The following is a description of a gene set: The posttranscriptional addition of methyl groups to specific residues in a tRNA molecule. species: Homo sapiens Human Gene Set: GOBP_TRNA_METHYLATION, and this is the list of marker genes: TRMT12, TRMT1L, THUMPD3, ALKBH8, TRMT9B, NSUN2, TRMT10A, METTL8, TRMT44, METTL2A, WDR6, TRMT61A, TYW3, WDR4, THUMPD2, TRMT6, TRDMT1, TARBP1, BCDIN3D, AKT1, METTL1, TRMT10B, NSUN3, HSD17B10 (hydroxysteroid 17-beta dehydrogenase 10), METTL2B, TRMT1, TRMT112, TRMT10C, TRMT5, FTSJ1, MTO1 (NCBI Gene Id 25821), TRMT61B, TRMT13, THADA, LCMT2, METTL6, DALRD3, TRMO, GTPBP3 (GTP binding protein 3, mitochondrial), NSUN6